Given this list of marker genes CITED2, FOCAD, ADAMTS19, MYH7, TMEM260 (NCBI Gene Id 54916), TWIST1, ELN, NKX2-5, TLL1, TBX20 (NCBI Gene Id 57057), GATA6, MYH6, ACTC1, GATA4, here is a description of the gene set: Human Gene Set: HP_SYSTOLIC_HEART_MURMUR Systolic heart murmur A heart murmur limited to systole, i.e., between the first and second heart sounds S1 and S2. species: Homo sapiens